Given this list of marker genes NBN, UBE2K, SLC52A2, SEMA3C, COL9A2, RPS6KA4, TMX4, ASB8, here is a description of the gene set: from publication Kang HC, Kim IJ, Park JH, Shin Y, Ku JL, Jung MS, Yoo BC, Kim HK, Park JG (PMID 14734480) Genes down-regulated in gastric cancer cell lines resistant to cisplatin. PURPOSE: A major obstacle in chemotherapy is treatment failure due to anticancer drug resistance. The emergence of acquired resistance results from host factors and genetic or epigenetic changes in the cancer cells. The purpose of this study was to identify differentially expressed genes associated with acquisition of resistance in human gastric cancer cells. EXPERIMENTAL DESIGN: We performed global gene expression analysis in the acquired drug-resistant gastric cancer cell lines to the commonly used drugs 5-fluorouracil, doxorubicin, and cisplatin using Affymetrix HG-U133A microarray. The gene expression patterns of 10 chemoresistant gastric cancer cell lines were compared with those of four parent cell lines using fold-change and Wilcoxon's test for data analysis. RESULTS: We identified over genes differentially expressed in 5-fluorouracil-, cisplatin-, or doxorubicin-resistant gastric cancer cell lines. Our expression analysis also identified eight multidrug resistance candidate genes that were associated with resistance to two or more of the tested chemotherapeutic agents. Among these, midkine (MDK), a heparin-binding growth factor, was overexpressed in all drug-resistant cell lines, strongly suggesting that MDK might contribute to multidrug resistance in gastric cancer cells. CONCLUSIONS: Our investigation provides comprehensive gene information associated with acquired resistance to anticancer drugs in gastric cancer cells and a basis for additional functional studies. studied in species Homo sapiens Human Gene Set: KANG_CISPLATIN_RESISTANCE_DN